Given this list of marker genes FADD (Fas associated via death domain), RIPK3, CASP8, TRADD, MLKL, RIPK1, TRAF2, here is a description of the gene set: Defective RIPK1-mediated regulated necrosis Human Gene Set: REACTOME_DEFECTIVE_RIPK1_MEDIATED_REGULATED_NECROSIS species: Homo sapiens